The following is a description of a gene set: Human Gene Set: GOBP_INTERLEUKIN_4_PRODUCTION species: Homo sapiens The appearance of interleukin-4 due to biosynthesis or secretion following a cellular stimulus, resulting in an increase in its intracellular or extracellular levels., and this is the list of marker genes: SLC7A5, HAVCR2, GATA3, NLRP3, LEF1, TNFSF4, LGALS9, IL1RAP, CEBPB, IL20RB, PRKCZ (NCBI Gene Id 5590, protein kinase C zeta), CLECL1P, HLA-E (NCBI Gene Id 3133), CD3E, PRG2, RARA, DDIT3, ZFPM1, NDFIP1 (Nedd4 family interacting protein 1), CD83, CD86, SASH3, SYK, MIR320A, SCGB1A1, ZP3, CD40LG, CD28, PRKCQ, EPX, IRF4, HLA-DRB1, IL33, FCER1G, FOXP3